The following is a description of a gene set: species: Homo sapiens Estradiol regulation in porto-sinusoidal vascular disease Human Gene Set: WP_ESTRADIOL_REGULATION_IN_PORTOSINUSOIDAL_VASCULAR_DISEASE, and this is the list of marker genes: ESR1, SP3, KCNN3, CALM1, SP1